The following is a description of a gene set: Functional abnormality of the gastrointestinal tract studied in species Homo sapiens Abnormal functionality of the gastrointestinal tract. Human Gene Set: HP_FUNCTIONAL_ABNORMALITY_OF_THE_GASTROINTESTINAL_TRACT, and this is the list of marker genes: ERCC6, CREBBP, CDKN2C, DOCK11, COLQ, PACS2, PHOX2B, PIGT, ATM, OPLAH, GEMIN4, PHEX, DPYSL5, GRIA1, FIG4, GIPC1, PRDM13, VAMP1, SKIC2, CARD8, SNAP25, FCHO1, MT-ND6, MT-TV, DHX9, CDH1, CASZ1, ZMYM3, MAN2B1, DPP9, PRKCSH, CPSF3, PTCH1, MVK, HMOX1, SCARB2, GLYCTK, SCN8A, HLA-DRB1, TRAPPC6B, CACNA1I, HEXB, F5, SYNJ1 (NCBI Gene Id 8867), SLC52A3, UNC13D (NCBI Gene Id 201294), CLCA4, SRD5A3, IRF5, CHRNE, CACNA1G, FZR1, DYSF, H3-3A, MT-ND1, DLG1, NPC2, FLNC, EHMT1, ACTG2, GABRD, GABBR2, FLII, POT1, IL10RA, PRDM12, AGR2, CDK4, BBS2, DHDDS (dehydrodolichyl diphosphate synthase subunit), CHAT, HLA-DPB1 (NCBI Gene Id 3115), EGFR, CORO1A, ECE1, GNB1, LAMB3, EDNRB, PFN1, CRLF1, DSP, SEC24C, PRKCG, NOTCH2NLC, SYT1, LYN, ARHGEF38, NGLY1, KIAA0586, SDHA, MCEE, ABCB1, PRMT7, SIX3, WNK1, NFKB2, AHDC1, EXT1, NOTCH3, ATP9A, POLR3A, GAS1, STUB1, TYMP, ATP6V1B2, REEP1, HPCA, MT-TF, PIGY, IL10, DAB1, HACD1, SH2B1, IKBKG, NOP10, FARSB, PKHD1, SGO1 (NCBI Gene Id 151648), PLOD1, MED12, SATB1, GABRA2, HSPG2, CALR, RACGAP1, BACH2, KAT6B, FH, MYH8, TRPV6, SKIC3, DYRK1A, ADAM17, SSR4, BUD23, PTEN, AFG3L2, POLR1A, COL5A1, PACS1, KCNN4, CCDC22, GTF2IRD2, ABCA3, FGFRL1, VWF, H3-3B, APOLD1, ENG, NIPBL, ATP1A2, ATP5F1A, MRPS28, MYL9, FARS2, MECP2, CAV1, MT-TS2, ACOX1, SATB2, CDC6, CACNA1A, IFT172, F2, ARL6, POLR2A, F9, COQ2, NCF4, GUCY2C, NOS1, PMS1, LMX1B, PAK1, LONP1, TGIF1, TNFRSF13B, CARD10, ERLIN2, TYMS, GRIN1, DCLRE1B, MYLK, MUC5B, ATXN2, PLA2G6, SZT2 (NCBI Gene Id 79597), ORC6, ABCC6, SLC25A24, MPV17, DHCR7, TP53 (NCBI Gene Id 7157), TSC2, DZIP1L, SLC2A3, TINF2, BBIP1, DCLRE1C, ATXN1, NOD2, NAA10, ABCD1, DAO (NCBI Gene Id 1610), BMP4, KIAA0319L, JAG1, MSR1, ALDH4A1, AAAS, PALLD, ALS2 (NCBI Gene Id 65058), DEF6, BRCA2, CHMP1A, IL12A, ARFGEF2, BBS5, BBS4, SPOP (NCBI Gene Id 8405), MCOLN1, KCND3, SLC12A2, BCL10, IL10RB, JAK3, ADNP, SETX (NCBI Gene Id 85506), PLAA, MEGF10, HNRNPK, B2M, ATXN3, GP1BB, SLC38A3, TNFRSF1A, TAP2, AMPD2, FLCN, CLMP, PCGF2, KCNA1, TREM2, KLRC4, GMNN, SYNGAP1, MSH2, STAT1, FERMT1, P4HA2, HNRNPH1, GNAQ, DLL1, ATP11A, CELF2, COL1A1, XYLT2, MGAT2, PDGFRB, CDKN1B, RUNX1 (RUNX family transcription factor 1), DNAJC13, FAH, SMARCA2, PARN, TRAK1, MLX, PTS, TAOK1, IKZF1, NCF2, NACC1, NALCN, PON2, GNB5, SRP19, GSTM3 (glutathione S-transferase mu 3), GRM7, SLC6A14, EXT2, DGUOK, ENPP1, NRTN (NCBI Gene Id 4902), XYLT1 (NCBI Gene Id 64131), FGA, PARS2, MYORG, VPS33A, SPG11, GABRA5, CNKSR2, NOTCH1, DKC1, CCR1, SEMA3E, ELANE, MLXIPL, CAMK2B, NDUFA9 (NCBI Gene Id 4721), NUTM2B-AS1, NEXMIF, SEPSECS, IL37, SQSTM1 (NCBI Gene Id 94002), PLVAP, ABCD4, NDUFS1, OPTN, MEFV, TTC19, IRF9, RIC1, PPARGC1A, HPRT1, XIAP, PYGM, CCNF, TRAPPC12, PRPS1, ATXN8OS, SLC37A4, RLIM, CNTNAP1, RNU4ATAC, PSMB10, ERBB3, ACTL6B, AARS1, EEF1A2, MED17, ERF, RNF170, DOCK6, MST1, HNRNPH2, WIPF1, PEX1, RBPJ, UCHL1, SEC63, MAP2K1, GP1BA, WDPCP, WT1, MASP2, PANK2, SREBF1, ANG, BMPR1A, CLP1, CDON, TRIM32, IRF6, PIK3CD, BBS7, KNSTRN, BRD4, FOXG1, LETM1, DPH5, CHRNA1, SLC26A9, PDE8B, FMR1, DCTN4, IRGM, KCNQ2, GRIN2D, TSC1, PRUNE1, RNF125, ITGB3, SPTLC2, BBS10, MKS1, PTPN22, SLC52A2, CHRND (cholinergic receptor nicotinic delta subunit), NONO, SIAH1, ARNT2, FASLG, CBL, HFE, NEFH, FCGR2A (Fc gamma receptor IIa), MAPK1, SPINK5, TBCE, MBD5, DDOST (dolichyl-diphosphooligosaccharide--protein glycosyltransferase non-catalytic subunit), EPCAM, SUCLA2, FGF8, LUZP1, SIN3A, SLC18A3, FGFR2, CDC73, FLT1, STAT4, ARF1, KCNQ3, UBE3A, GPRC5B, TNFSF15, ASXL3 (NCBI Gene Id 80816), SMC3, AQP4, DTYMK, ATP2B3, CTCF, CAD, GPIHBP1, SNF8, FCSK, UNC45A, FLAD1, LRRK2, GALC, PSPH, TERC, EXOSC9, BAZ1B, MCFD2, POLD1, APC2, SYT2, NDUFA13, HDAC8, GTF2I, LTBP4 (NCBI Gene Id 8425), FBXW7, MUSK (NCBI Gene Id 4593), SLC46A1, PNKD, SMC1A, VCP, CD3G (CD3 gamma subunit of T-cell receptor complex), CARD11, MAP3K20, VPS13A, FCGR2C, COX11, HLA-B (major histocompatibility complex, class I, B), GRHL2, RERE, MUTYH, HECTD4, HLA-DQB1, SRPX2, PRDX3, NEU1, CCND1, APP, VARS1, ZFX, COL7A1, KMT2D, AFF4, MAPK8IP3 (mitogen-activated protein kinase 8 interacting protein 3), AGRN, TFAP2A, IFT27, CHD7, KIF1A, COL4A6, RAI1, RPS20, MRPS25, IL21R, TBCD, CLN8, PPM1D, KCNC2, SDHD, TSEN34, GBA1, KLHL7 (kelch like family member 7), ADAT3, ERCC8, RNASEH1, UNC45B, ALDH18A1, RPL11, TTC7A, DISP1, PSEN1, GJB1, SPART, CFAP410, NEPRO, CLCN1, FAS, LRP12 (LDL receptor related protein 12), IFNGR1, TSEN15, STAG2, HOXB1, SPEN, SPG7, VPS11, NECTIN1, ATP7B, FLVCR1, MAP2K2, NTNG1, POGZ, ITGA2, ALG9, KMT2A, RIPK1 (NCBI Gene Id 8737), MYT1L, POLG, MTHFS, CLTC, UBTF, KCNK9, LMNB1, USP7, SON, ANAPC1, NR4A2, TARDBP, HMBS, MAPT, AGO2, KBTBD13, PYCR1, EIF4A2, LRPPRC, NOP56, LRBA, SPTSSA, TOR1A, SLC6A5, CTHRC1, PLP1, SYT14, CAVIN1, LMNA, YARS2, PIK3R5, F11, SLC5A7, LIG4, LAMA2, ALDOB, MRPS34, ACTA1, POU2AF1, GDAP2, SLCO2A1, PHGDH, CEP85L, ASCC3, BBS1, SERPINA1, SLC2A10, IFT74, SPTAN1, PRKCZ, POLG2 (NCBI Gene Id 11232), BICRA, CNBP, DDHD2, WAS, SERPINE1, UBQLN2, ECM1, NUS1, FKRP, COBLL1, ATN1, VRK1, CD55, YY1, RTEL1, SRSF2, MT-TQ, ASCL1, COG7, RAD21, PSAP, DNM1, LBR, F13A1, SLC11A1, DCTN1, PIGQ, GDF2, EPHB2, PIGA, IDH1 (isocitrate dehydrogenase (NADP(+)) 1), FGFR1, NKX2-5, STAT6, SOX10, CDKL5, GLI2, GUCY1A1, TCF4, MECR, INAVA, ARHGAP31, RBCK1, GFI1, POR, MED25, AGO1, YWHAG, CTNS, HLA-DPA1, COL4A5, FOXP3, HMGA2, EDN3, CHMP2B, RELN, PON3, CDKN2B, LIMK1, HPDL, MINPP1, DCX, NTRK1, SLC44A1, TBP, ERAP1, ADCY6, DSG1, MED12L, SOX5, MITF, COL5A2, MMEL1, ASNS, PIK3CG, TCEAL1 (transcription elongation factor A like 1), TPM2, TIMM8A, FGG, KIF26A, UFC1, ANO1, ZAP70, MAP1B, NSD1, POLE, GOSR2, NDUFS3, ARHGAP29, ADAMTSL2, MMP23B, SMAD3, DNAAF4, GIGYF2, PRTN3, TCIRG1, ZBTB7A, SEMA3D, CTLA4, PNP, ATP6V0A1 (ATPase H+ transporting V0 subunit a1), PRNP, CDKN1A, SLC1A2, VPS37D, CBS, KCNB1, ZNF699, LIFR, MACF1, PDGFRA, BRCA1, CTNNB1, FBXO28, FXN, NUP54, HEPACAM, KATNB1, TUBB4A, ERMARD, DALRD3, EWSR1, ZIC2, ATAD1, LZTFL1, COG6, GNS, TBK1, PLCG2, SLC6A8, PI4KA, PPP3CA, ITGA2B, WASHC5, HTRA2, FTL, NLRC4, TAF6, STX1A, SELENON, SEMA4A, SAMD9, ACVRL1, SCN1B, AR, CD109, SETBP1 (SET binding protein 1), IRF4, FCN3, MEIS2, FNIP1, GREM1, VAC14, AOPEP, COG4, MYD88, PALB2 (partner and localizer of BRCA2), NEUROD2, HIVEP2, TSPYL1, KMT2B, REPS1, MEN1, TSEN2, NFKBIA, HPS1, RPL10, F8, ATP1A3, GPHN, PYROXD1, TERT, ATXN7, IRF2BPL, SLC9A3, CFTR, CLPB, RETREG1, C4A, TBC1D24, SLC13A5, MPI, F7, CHAMP1, AP3B1, TPM3, SMG9, NCAPG2, CEACAM6, SACS, GLE1, CYP7B1, B4GALNT1, ADAMTS2, JMJD1C, PABPN1, SLC32A1, GCLC, NUP62, MYC, DMXL2, TRAPPC11, DLX4, COL17A1, GABRG2, MT-TK, SEC23A, METTL27, RARS2, MT-ATP8, HLA-DQA1, KLHL40, GCDH, GLA, GPR35, TAF1, ARCN1, AICDA, KIT, NEB, PLXND1, CCDC47, POLA1, ZMYM2, SHH, BLM, SNCA, PDPN, NEFL, MNX1, FAM13A, C1GALT1C1, CAMK2A, FBN1 (fibrillin 1), STXBP2, ATP13A2, RRM2B, CPLX1, TGFBR1, KIF23, MAP3K7, SCUBE3, ANKRD11, DMPK, RFC2, HMGCR, SYK, TSEN54, CENPT, IL12A-AS1, SPTLC1, MAB21L1, CYFIP2, TGFB3, CLCN4, IL21, SOX9, AP3B2, NFIX, PORCN, AFF3, CLIP2, SHARPIN, EIF4G1, EIF5A, ARVCF, PTRHD1, LYRM4, FGF12 (NCBI Gene Id 2257), COL2A1, CASK, RFX5, REV3L, SCN9A, SMO, SI, CCR6, BBS9, EIF4H, EPRS1, HNRNPA1, CORIN, PRKRA, TPP1, IFT56, PIK3CA, MT-CO3, XRCC1, TBX4, TMEM270, NBN, TOP3A, PMP22, SUPT16H, EDEM3, POLR3B, DES, NDUFA6, SDHC, EXOSC5, ADAR, WARS2 (tryptophanyl tRNA synthetase 2, mitochondrial), MSL3, MIF, TNPO3, IL6ST, KCNA2, ZEB2, OCA2 (NCBI Gene Id 4948), EDNRA, MYMK, DOCK2, IDH2, SCN2A, GFPT1, SLC25A22, SKI, ELP1, NPHP1, DST, SLC6A3, SLC25A4, RFXAP, GDNF, HSD3B7, JAK1, SUCLG1, MYH2, MT-TL1, ACTB, ATG7, LMAN1, RABL3, MRAP, CDK13, MFF, TGFB1, F10, SNRPB, DDB1, STAC3, OCRL, DOCK8, CHEK2, NF1, TK2, NSD2, MAN2C1, STAT3, ASXL1, ALG12, IL12RB1, ERBB2, NEK1, WWOX, IDS, JAK2, CAMTA1, ARV1, STXBP1, ARX, VPS35L, MYO1H, ALG2, MYH11, IQSEC2, SPIB, CTBP1, STN1, PAX7, CSF1R, UNC13A, SALL1, PIGP, SHANK3, TTC8, CPOX, USP9X, TYROBP, TECPR2, OPA1, PUF60, KCNH1 (potassium voltage-gated channel subfamily H member 1), SPG21, MT-TH, TET2, MYO9A, RET, TRIM8, SCLT1, MYOT, SRCAP, MPZ, ACTA2, SIK1, ENSG00000288330, ASAH1, TMEM94, HSD17B10, ITGA7, ATL1, TGM6, FGB, UBA5, SDHB (NCBI Gene Id 96200), CASP10, SIGMAR1, MID1, RFXANK, SLC1A4, CD3E, HCN1, ERBB4, GON7, ITPR1, SLC35C1, COQ4, MYH14, PIEZO1, ZSWIM6, SDCCAG8, TTBK2, VPS35, HTT, TFG, SMC5, PSTPIP1, TRIP4, SOD1, HNRNPA2B1, EOGT, SLC9A6, DLL4, NODAL, TREX1, GRM1, MT-ND4, SMAD4, CARS2, AGGF1, PRDM16, FBXO7, PRPH, NSUN2, ACADVL, TNFAIP3, CTC1, ARID2, ATL3, GNAS, ATP7A, CARMIL2, CSPP1, ATP6V1A, NUP214, RRM1, ZC4H2, PGM3, SEC61A1, DNAJC30, SLC19A2, HIRA, PUS3, GNB2, MGME1, NCF1, NPHS1, COL13A1, MLH1, KY, RHBDF2, UBAC2, FRG1, ITCH, NDUFAF2, ZFYVE26 (zinc finger FYVE-type containing 26), PLCH1, TMTC3, FUS, UFD1, IPO8, BBS12, CYP27A1, LRP5, SPTBN4, CACNA1B, KCNAB2, SLC6A9, NAA60, NPC1, TWIST1, SCAPER, CACNA2D1, H4C5 (NCBI Gene Id 8367), FLNA, MT-ATP6, VPS13C, IVNS1ABP, CHCHD10, SERPING1, TLR4, BAP1, CACNA1C, GRB10, MSX1, PNKP, STX11, HTRA1, ELF4, ZBTB18, ERCC2, TEK, CIITA, ANXA11, MYL2, SLC25A1, APC, SEMA3C, GCH1, IL7R, MT-ND2, NRXN1, TBX1, CEP290, IL23R, MT-CO1 (NCBI Gene Id 4512), CFAP418, RECQL4, WFS1, ORC4, GNAO1, HPGD, TP63, GABRB2, GP9, SNCAIP, NDE1, EBF3, TRIO, TRMT10C, SEC31A, TAMM41, SFTPC, PCNA, GRHL3, FZD2, FOXN1 (NCBI Gene Id 8456), CRIPTO, TBL2, FGF10, LIG3, TWNK, ARSL, DNAJB6, AMER1, CEP19, LAMA3, CHD8 (chromodomain helicase DNA binding protein 8), IL12B, RREB1, AFG2A, MKKS, MTRFR (NCBI Gene Id 91574), ATXN10, HGSNAT, STIL, PIEZO2, KAT6A, DNM1L, MYPN, SV2A, HRAS, SLC35A2, FOXH1, NECAP1, FTH1, ATRX, TNNT1, PHIP, SLC1A3, TIMM22, GLRA1, NRCAM, FKBP6, TGFB2, QDPR, RARS1, FGFR3 (fibroblast growth factor receptor 3), ASCC1, PDHA1 (NCBI Gene Id 5160), KCNC3, TGFBR2, CDKN2A, SCN1A, TUBB6, EP300, PDP1, GTF2IRD1, PON1, GFI1B, KMT2C, MSH6, GLB1, BRAF, ADD3, MAGEL2, IL6, PLIN4, SFTPA2, CEACAM3, SLC19A3, CRYAB, STAG1, KIF5A, IARS1, EFEMP1, DNASE2, DDC, ADGRG1, CHRNA3, CCN2, ALMS1, TXN2, CISD2, MT-ND3, PMS2, GFAP, PAX8, FBXO11, KLHL41, NTRK2, PTPN6, UBB, ARPC5, PEX16, RNU4-2, DKK1, FA2H, LAMC2, CAPRIN1, MB, GBA2, NEDD4L, VAPB, COMT, STOX1, GMPPA (GDP-mannose pyrophosphorylase A), TANGO2, STK11, GLT8D1, UBE4B, IFIH1, MT-TW, MDM2, LMOD3, NF2, MT-ND5, FOXP2, DEAF1 (DEAF1 transcription factor), MMP1, SCN3A (NCBI Gene Id 6328), AASS (aminoadipate-semialdehyde synthase), AMACR, TNXB, DDIT3, UBR7, LMOD1, MT-CO2, REL, SLC25A13, SEMA4D, ELN, ADH1C, SCN4A (NCBI Gene Id 6329), IARS2, ASPA, ARPC1B, MATR3, SP110, GLRB, PPOX, CDK19, LAMB2, FBXL4, SFTPA1, MADD, PRF1, GSN, CYBC1, RILPL1, PIGN, F13B, COL3A1, TAF15, ORC1, MT-TT, PLEC, KRAS, NSRP1, KDM6A, APOE, TBC1D23, WDR26, WAC, EPG5